Given this list of marker genes Cdk4, Ccnd1, Ccnd3, Cdk6 (NCBI Gene Id 330039), Ccnd2, here is a description of the gene set: Mouse Gene Set: REACTOME_DRUG_MEDIATED_INHIBITION_OF_CDK4_CDK6_ACTIVITY studied in species Mus musculus Drug-mediated inhibition of CDK4/CDK6 activity